The following is a description of a gene set: electronically inferred by orthology from the curated human pathway part of: Apoptosis studied in species Mus musculus Reactome Pathway: Regulation of Apoptosis This event has been computationally inferred from an event that has been demonstrated in another species.<p>The inference is based on the homology mapping from PANTHER. Briefly, reactions for which all involved PhysicalEntities (in input, output and catalyst) have a mapped orthologue/paralogue (for complexes at least 75% of components must have a mapping) are inferred to the other species., and this is the list of marker genes: Opa1, Oma1